Given this list of marker genes WAPL, ESPL1, ATRX (NCBI Gene Id 6475), TNKS, NAA10, here is a description of the gene set: studied in species Homo sapiens Any process that stops, prevents, or reduces the frequency, rate or extent of sister chromatid cohesion. Human Gene Set: GOBP_NEGATIVE_REGULATION_OF_SISTER_CHROMATID_COHESION